Given this list of marker genes Cryaa, B2m, Hspa2, Dnaja4, Dnajb2, Hspb2, Hspa1a, Bag5, Hsp90aa1, Hspa5 (heat shock protein 5), Hspa8 (heat shock protein 8), St13, Hspa14, Hspa1l, Hspa13, Hspb1, Dnaja2, Hspb6, Dnaja1, Pdcl, Cryab, Hspa9, Hspa1b, Hspd1, here is a description of the gene set: Mouse Gene Set: GOBP_PROTEIN_REFOLDING The process carried out by a cell that restores the biological activity of an unfolded or misfolded protein, using helper proteins such as chaperones. species: Mus musculus